The following is a description of a gene set: Genes predicted to be targets of miRBase v22 microRNA hsa-miR-3158-5p in miRDB v6.0 with MirTarget v4 prediction scores > 80 (high confidence targets). from publication Chen Y, Wang X (PMID 31504780) Human Gene Set: MIR3158_5P studied in species Homo sapiens, and this is the list of marker genes: PATZ1, LDB3, MANEA, COP1, TUB, CTNND1, ZFR, GARIN6, KCND2, MAEA, AHCYL1, PFKFB3, ZC3HAV1L, SLC25A38, PRPF19, ERBB2 (erb-b2 receptor tyrosine kinase 2), PPP4R3A, SPRYD7, KIAA0513 (NCBI Gene Id 9764), FIGN, ZMYM6, CKLF, SNTG2, FANCD2OS, CCDC6, ENC1, SRSF7, HMGN3, E2F7, ARPC2, FAF2 (Fas associated factor family member 2), TRIM7, RAPGEF6, CAMTA1, CLSPN, COL12A1, SGK3, GATB, UBE2B, C17orf107, GGA2, MTMR2, DST, KAT7, TEAD1, CPEB4, HDAC1, ABCA13, BTAF1, ASTN1, SP1, TNRC6B, SFRP1, TNFRSF1B, CTNNA3, CHRFAM7A, RAP1GDS1, GLTP, ARHGEF10, HTR3E, TDRKH, SHISA9, DNER, TNFRSF19, IPO8, CNOT2, SMCO1, FAM219B, SETD3, RP1L1, RPP14, NUFIP2, FXR1, GLUD1, IKZF3, HIPK1, NT5C2, TGFB2, FIBIN, PGAP4, ADAM7, WNK3, POLDIP2, TNFSF8, MEF2A, GPC4, VKORC1L1, KCNQ3, SMARCE1, HBEGF, TAL1 (NCBI Gene Id 6886), MYORG, PGRMC1, USP9X, PTCHD1, RNF19A, CDKL4, PTPN2, RPL15, TMEM62, MN1, HACD2, EPHA4, DICER1, BCL6, CORO2B, THOC5, RAB30, DNAJC6, SH3PXD2A, CAMSAP2, NOD1, CLEC14A, ICE1, AMOTL1, CIT, RELN, CEP15, KCTD9, KCNA1, GYG1, FAT3, ATP6V1C1, SMAD4, ARHGAP20, EIF2AK2, CHST2, CALN1, ADAM22, PPM1A, UGGT1, IL10RA, PSD3, CARS1, OCM2, SERTAD2, MED13L, HSPA12A, KHDC4, WDR47, RPGRIP1L (NCBI Gene Id 23322), FAM98A, NIPBL, WWTR1, RNF187, THPO, C8orf44-SGK3, ETF1, PGM3, TTYH2, PHACTR3, NUDT7, MAP1B, FAM43B, WSB1, APRG1, RASSF10, CHRNA7, EHD4, ZNF780A, RCOR1, ZNF566, EPB41, PHF24, HIP1R, SLC2A10, MARK4 (microtubule affinity regulating kinase 4), HTR1B, UCHL1, PPP1R2